Given this list of marker genes EIF2AK1, SEC31A, SCAMP2, MAGEH1 (MAGE family member H1), CTC1, ASCC3, METTL22, TLE1, PLAAT4, MINDY1 (MINDY lysine 48 deubiquitinase 1), UAP1, IQGAP2 (IQ motif containing GTPase activating protein 2), PCDHGA9, H2AC6, PPP4R3B, CBY1, SGCA, UFC1, THAP11, TBL2, CORO7, NAT1, NAGPA, FBXO2, POMC, TESMIN, ISOC1, NDUFA6, REX1BD, EID1, SPACA9, GORASP1, HSPB1, CTSF, RPS6KB2, PCK2, GORASP2, CERS2, CFAP410, ATP6AP2, RAB3A, ITPK1, ST6GALNAC4, H2BC12, ISCU, BAIAP3, RCE1, THAP7, SCAMP3, MT2A, COG2, EPHB6, SLC35A1, DECR1, SURF1, FAM89B, SECISBP2L, SERP1, C10orf95-AS1, STUB1, SEC63, YIPF1, TBX2, ANXA2 (NCBI Gene Id 792), ATP6V0E2, RBKS, HTATIP2, INS, RNF31, MSL1, LGALS1, ADAM8, ING4, HSPA1L, FAM114A2, HMGN4, H2BC6, IFT52, DAPK2, CALHM2, PLA2G4C, H1-10, COPZ1, RRP8, KANK2, EFHC1, KCNQ2, LMAN2, PTPN22, CENPB, FOXC1 (forkhead box C1), FDX1, ITGB1, ACBD4, KLF8, APOBEC3B, CDK14 (cyclin dependent kinase 14), OSBPL10, FXYD1, UFSP2, MGAT2, NDUFA3, FAIM, GPX7, EBP, USP18, TMED3, SLC25A23, URM1, CD99, ACSF2, MCRS1, TP53TG5, ERP29, OAS2, ATP6V0E1, ACAD8, COQ4, COQ2, ZFAND6, SCAPER, MYO1F, CNKSR1, PTPRA (protein tyrosine phosphatase receptor type A), ZDHHC4, TMSB10, DERL2, BPNT2, ACOT8, ARFGAP3, CTSA, NFE2 (nuclear factor, erythroid 2), ANXA2P2, ZBTB32, TMEM184B, TRAM1, S100A6, SLC2A11, NDFIP1 (Nedd4 family interacting protein 1), ECHDC2, DNAL4, CD86, DIPK1A, IGLV4-60, TINF2, DAP, AHSG, AKT3, IGHA1, WDR45, LCP2, MICU2, RHOB, LBX1, DRC3, PPP1R2, GABARAP, DPAGT1, ATP8B2, GLS, ITFG1, JHY (junctional cadherin complex regulator), ZMPSTE24, PPIE, PIEZO1, CNR2, AUP1, HSPA13, ISG20, THBS3, ALG3, STK11, TKFC, CD27, CHCHD3, GUSB, SLC27A3, ITGA3, CITED1, TUBGCP4, PPOX, NAALADL1, INTS5, PREB, PRAF2, CRELD1 (NCBI Gene Id 78987), ATF6, UBXN6, SNAPC3, CHMP6, PIGP, PRDM16, HPCA (hippocalcin), HLA-J, RSAD1, BTD, CHST12, FAM30A, TMED10, here is a description of the gene set: studied in species Homo sapiens B cells from human tonsil and blood were sorted using flow cytometry. The human samples were processed immediately ex-vivo using markers for known B cell subsets. from publication Longo NS, Lugar PL, Yavuz S, Zhang W, Krijger PH, Russ DE, Jima DD, Dave SS, Grammer AC, Lipsky PE (PMID 19023113) Genes up-regulated in comparison of IgD- peripheral blood B cells versus pre-germinal center B cells. Human Gene Set: GSE12845_IGD_NEG_BLOOD_VS_PRE_GC_TONSIL_BCELL_UP